Given this list of marker genes TMEM150A, CLIP4, DNAJC27, TRIP10, CD79B, SENP2, CPNE6, EBF1, ITGB3BP, CLEC4A, MAGI2, DCBLD2, ERBB2, CAMK1, AGR2, SRMS (NCBI Gene Id 6725), RASA4, TMEM141, TMPRSS3, LYL1, GHR, LMNA, NGF, IL4I1, PCSK6, F11, BPIFB1, CABP2, PRSS44P (NCBI Gene Id 729756), HLA-DRB1, FOXA1, PKP2, PDE6G, BRWD1, SERPINB2, RGS14 (NCBI Gene Id 10636), FNDC10, RGL2, CORO2A, RGS6, MYO15B, MGAT1, TAS1R3, TRIM60, SERPINI2, COL25A1, SH3BP2, LIFR, ACTN2, FAM114A1, CIITA, HIPK2, CFAP298, PTP4A3, CASK, CCDC137, ANTXR1, MYO1C, IBSP, GBF1, SLC38A3, TMEM40, SH2B1, HLA-DOA, GPLD1, GGA2, IL1B, NR1I2, FBL, TPBG, MAZ, VPS37B, CTSH, HSD17B1, ST6GALNAC2, DNAH8, TEC, KRT35, SCD, HSPB2, CIMIP2A, AGXT, NKX2-8, RTL8B, CNN3, EPS8L2, POU1F1, UNC93B1, LRRC2, SELL, CYSRT1, PKD2, CSF2RB, GRIA1, CAVIN4, STC1, MYLK, P2RX5, IGFBP2, DNAJC11 (DnaJ heat shock protein family (Hsp40) member C11), KCNMA1, PHOX2A, C2orf80, WBP1L, SGCE, TMEM266, TNRC6C, GAS7, CD40, KLHL11, CBS, RUNDC3A, TSPAN9, FMNL1, HIP1R, GAS8, OXNAD1 (oxidoreductase NAD binding domain containing 1), CD72, MMP10, ADGRE5, MAP3K21, IFT140, HSPA1B, MAP3K14, FANCG, SEC16A, GPR84, TNFRSF13C, TREM2, OAS2, CMPK2 (cytidine/uridine monophosphate kinase 2), KCNB1, CLDN3, INMT, SMAD9, NFKB2, CD8B, ACOT12, MYLK2, IKZF4, SCN3B, FBXW4 (F-box and WD repeat domain containing 4), QTRT2, KMO, CIT, CD19, CYP4F3, ICOSLG, PLA2G2C, HSPB1, FKBP8, CPEB3, TLX1, SORL1, BBS9, MS4A1, CTRC, MAPK8IP1, KIF17, PCP4, HLA-DMA, SOX12, BEX1, BLNK, CD74, HEMK1, BTK, COLQ, CYP2C8, SESN1, PHKA2, MGAT5, CR2, SPIB, BCAR3, C2orf42 (chromosome 2 open reading frame 42), SEMA4A, RARRES2, DZIP1, PHETA2, FZD4, NDST3 (NCBI Gene Id 9348), GRIK3, CHRND, PAX4, DPP3, CD79A, BCL11A, PPP1R37, H1-10, ABHD15, ZDHHC14, SLAMF9, FGD2, SLIT3, ARID3B, SLC16A4, AVP, ARMC12, SCARA5, here is a description of the gene set: from publication Takii R, Inouye S, Fujimoto M, Nakamura T, Shinkawa T, Prakasam R, Tan K, Hayashida N, Ichikawa H, Hai T, Nakai A (PMID 20018623) Human Gene Set: GSE16266_CTRL_VS_LPS_STIM_MEF_DN To clarify inflammatory genes whose expression is suppressed at high temperatures, we performed comprehensive analysis of gene expression by using a DNA microarray. Two independent primary cultures of mouse embryo fibroblasts (MEF1 and MEF2) were treated with LPS for 4 hours, or treated with LPS for 4 hours after the pretreatment with heat shock at 42˚C for 1 hour, and we identified genes that undergo more than a 3-fold increase with LPS treatment. Remarkably, genes (86%) underwent less than a 2-fold increase after combined treatments with heat shock and LPS in MEF1 and MEF2 cells. studied in species Homo sapiens Genes down-regulated in mouse embryonic fibroblasts (MEF): control versus LPS.